The following is a description of a gene set: species: Homo sapiens Genes up-regulated in bone marrow-derived macrophages at 45 min of stimulation by LPS: IL6 knockout versus IL10 knockout. Human Gene Set: GSE5589_IL6_KO_VS_IL10_KO_LPS_STIM_MACROPHAGE_45MIN_UP IL-10 or IL-6 stimulation of control 129xC57BL/6 murine bone marrow derived macrophages in the presence of LPS. We used microarrays to detail the global programme of gene expression changes in response to IL-6 or IL-10 stimulation in the presence of lipopolysaccharide. BMDMs were isolated from control, IL-6-/-, and IL-10-/- mice on a 129XBL/6 mixed background mice and differentiated in the presence of CSF-1 for 6-7 days. Cells were scraped and plated in 6 well plates at 2x10e6/well. Cells were washed with complete DMEM and rested for 1-2 hr before stimulation with combinations of IL-10 (10 ng/ml), IL-6 (2 ng/ml) or LPS (100 ng/ml) for 45 min or 180 mins. Complete biological replicates were performed. from publication El Kasmi KC, Holst J, Coffre M, Mielke L, de Pauw A, Lhocine N, Smith AM, Rutschman R, Kaushal D, Shen Y, Suda T, Donnelly RP, Myers MG Jr, Alexander W, Vignali DA, Watowich SS, Ernst M, Hilton DJ, Murray PJ (PMID 17114459), and this is the list of marker genes: PADI2, MMD, PKIB, MTRF1L, GALNT4, DGKD, DDX23 (DEAD-box helicase 23), RNPS1, HSD17B7, MED4, ASS1, VTA1 (vesicle trafficking 1), BCL2L1, NELFB, LPGAT1, SLC9A5, NOA1, NEU1, PLEKHA8 (pleckstrin homology domain containing A8), CARHSP1, TADA1, ARHGAP45, HELQ, TIAL1, BOD1L1, ADK (adenosine kinase), LANCL2, KIFAP3 (kinesin associated protein 3), PKP4, E2F2, PCCB, GPR176, MAGED1, TRAF3IP3, RCBTB2, TSHZ1, ERLIN1, ZMPSTE24, STK38, TRIM21, SAMD9L, CD300LF, APBB1IP, KLC4, ERCC6L, CENPJ, ROGDI, C18orf32, CD5L, GAS2L3, CCN1, APAF1, ABCG2, C16orf74, EXOC1, MSS51 (NCBI Gene Id 118490), WWP2, WWC2, CCNK, TMEM43, MYL6, EEA1, WDR90, PADI4, CERT1, CPT1C, IPO8, WDFY3, KDM3B, PPT1, GNG12, CD33, RPP21, GSDME, BEND4 (NCBI Gene Id 389206), VMA21, KDSR, SH3BP5L, SLC7A6, ARHGAP1, PRAF2, DHRS4, PARPBP (NCBI Gene Id 55010), KLHL20, RPAP3 (NCBI Gene Id 79657), DEDD2, CNN2, DYNC2LI1, SRL, ZNF658, SLC35E3, FASN, RINT1, PTK2B, CTBP1, RPS6KA5, ZIK1, AFP, KIF13B, WASHC1, TBC1D9B, MBP, CPSF1, PABIR2, TRAPPC2L, BEND6, CLN6, HOOK2, CFAP410, CDK14, MS4A6A, NFXL1, MEX3B, IFT74, RBM44, INTS13, LAMC1, VPS37C, MRPS33, DIPK2A (NCBI Gene Id 205428), CLEC4D, MFSD13A, FTH1, ACAT1, CAMP, CRLF3, SHC4, MAN1C1, TTC7A, NIPAL3, NCBP2AS2, CHCHD2, LPCAT2, PLXNB2, MAP3K5, C1QB (complement C1q B chain), TMEM184C, SLC30A5, EXOC4, SRRM1, SERPINE1, ANKRD13A, MTMR6, HNRNPDL, BLMH, TOMM7, ABHD8, CDK16, USP22, GPD2 (glycerol-3-phosphate dehydrogenase 2), ZFAND2A, HEXA, AGO4, MBD4, RAPGEF6, B9D1, ITGB3BP, HSPB6, DAB2, ESR1, MKNK2, USP15 (NCBI Gene Id 9958), KANSL1, NCBP2, MOB2, RAB3GAP1, VPS26A, CCM2, EBPL, SERHL2, SMAGP, GPR34, UBAP2L, PLOD1, MRPS18C, FAM177A1, HDAC6, AGBL5, RAB3D, RIF1, CC2D1B, PAFAH1B3, TEDC1, ZFYVE26, RALGPS2, SASH1, GNPAT, RXRA, ARHGAP4, ABHD17A (NCBI Gene Id 81926), SACS, RASSF2, SRP14, SLC9A9, G6PD, STX2, GXYLT1, SRGAP2, TRIM32, UAP1